The following is a description of a gene set: Mouse Gene Set: GOMF_PROTON_CHANNEL_ACTIVITY Enables the facilitated diffusion of a hydrogen ion (by an energy-independent process) involving passage through a transmembrane aqueous pore or channel without evidence for a carrier-mediated mechanism. studied in species Mus musculus, and this is the list of marker genes: Otop3, Atp5mf, Otop1, Otop2, Tmem175, Atp6v1a, Atp5po, mt-Atp8, Atp5f1b, Cybb, Atp5f1d, Atp5f1c, Atp5f1e, Atg5lrt, Atp5pd, Hvcn1, Sting1, Atp5mc1, Atp5pb, Atp6-ps, Slc4a11, Asic5, mt-Atp6, Atp5mg, Atp5pf, Atp5f1a, Atp5me